The following is a description of a gene set: Genes down-regulated in NB4 cells (acute promyelocytic leukemia, APL) in response to tretinoin; based on Chip-seq data. from publication Martens JH, Brinkman AB, Simmer F, Francoijs KJ, Nebbioso A, Ferrara F, Altucci L, Stunnenberg HG (PMID 20159609) Human Gene Set: MARTENS_TRETINOIN_RESPONSE_DN species: Homo sapiens Many different molecular mechanisms have been associated with PML-RARalpha-dependent transformation of hematopoietic progenitors. Here, we identified high confidence PML-RARalpha binding sites in an acute promyelocytic leukemia (APL) cell line and in two APL primary blasts. We found colocalization of PML-RARalpha with RXR to the vast majority of these binding regions. Genome-wide epigenetic studies revealed that treatment with pharmacological doses of all-trans retinoic acid induces changes in H3 acetylation, but not H3K27me3, H3K9me3, or DNA methylation at the PML-RARalpha/RXR binding sites or at nearby target genes. Our results suggest that PML-RARalpha/RXR functions as a local chromatin modulator and that specific recruitment of histone deacetylase activities to genes important for hematopoietic differentiation, RAR signaling, and epigenetic control is crucial to its transforming potential., and this is the list of marker genes: TUFM, PTMA, DMAC1, MMACHC, HMGA1, C2orf69, ZNF594, VMA21, PNN, SNORD52, NDUFA11, HSP90AB1, GLA, RACK1, AK2, TUBB1, ATP5MC3, RRP7BP, MYBBP1A, ITPKA, TRIM65, H2AJ, FAM180B, H3C13, NUDT16L1 (nudix hydrolase 16 like 1), PRMT6, TBRG4, C11orf91, YDJC, REXO4, HSD17B8, SRSF1, HNRNPH1, TUBB3, RPL26, FARSA, PRRG2, PSMD7, CABLES2, EIF5A, UNCX, CITED4, CHRNG, THUMPD3, ZBTB3, ZNF512B, LDHB, PROCA1, RPL21P28, ZNF785, ELOVL1, RABEP1, NOP16, RFC4, PDHB, PABPN1, RPL13AP20, FRAT1, FAM120AOS, SFT2D3, GNRHR2, CDT1, MRPL57, KIAA1143, GTPBP8, MICAL1, UNC79, ENTR1, RPL5, TMEM102, CHCHD2, TRAPPC4, VIM, ZNF324, HNRNPK, TIGD5, TSSK6, ABT1, ZBTB33 (zinc finger and BTB domain containing 33), H4C5, SNORD33, RASSF1, ESD (esterase D), NABP1, NDUFA4L2, CCDC54, SNORD19B, RXFP4, ERAL1, HOXC11, TEKT2, H4C16, KIAA1586, CEBPB, FAM136A, TMEM216, CSNK1D, COX17, CYTL1, RABGGTB, CCNA2, RECQL4, GLS2, C8orf33, OR7G2, IRX3, NLE1, CD68, RAN, C6orf120, FBXL18, RPS23, HMGN2, ZNF598, RPL24, UMPS, PHOX2A, MRPS7, MIR1915HG, TLCD1, H3C3, MALSU1, ACADVL, SNORA56, MAPK7, POU4F2, PA2G4, UQCRQ, FBXW9, SLC35A2, ZNF628, NDUFB10, WFIKKN1, NAA50, CDV3, RPL34, IL2RG, TUBA1C, ANKRD49, GLT8D1, ARRDC3, SCO2, RRAS, MCM6, BABAM1, RPS8, ATG4D, SLC43A3, FOSL1, HNRNPM, ARL4D, IDH3B, CNPY2, IQCG, SLC2A4RG, IQCC, NFE2L3, SNORD24, SNORD86, MRPS16, RPL37, THAP7, EME2, NDUFB11, TRIAP1, ACD, HDGF, LAT2, C6orf132, KLF1, PRSS53 (serine protease 53), RFESD, ATP5F1E, RPL23, UQCRB, FAM89B, RPL30, IFT22, TYSND1, NAXE, PURB, METRN, RAB26, PPIB, PRMT1, RNF5, RPS4X, AQP11, NRN1L, EIF5, SCNM1, MFSD4B, PDCD4, C20orf204, SLC38A2, SYNGR2, HYAL3, SNORD4A, MYL6B, CCT4, MAZ, CIMAP1B, THAP1, SNHG4, HNRNPL, RPS9, HNRNPDL, EEF1A1, RASL11A, KAZALD1, EIF5AL1, DCXR, PCBP1, RPL35, RPS16, SOX18, TRIM28, TMEM138, SNORA63, PPCS, TMEM129, TSR1, C6orf62, UBL4A, RPL13A, NIP7, CCT5, E2F8, FGFBP3, MYL5, REX1BD, ZNF200, EIF4A2, NOG, TCP1, MKRN3, RPL36, ARRDC1-AS1, PRTN3, ATF4, FRAT2, RPL10, PRDX5, BRICD5, PRR22, C1orf43, TRNT1, FZD1, TRIM41, RPS6KB2, HOXD13, ZSCAN32, PABPC1, TRIM72, RPL9, RPL18A, ATRAID, SNORD21, RPSA, HAGHL, OXLD1, CYP27B1, DRAP1, SNORA62, ZFAS1, RPL23A, RAD23A, SETD9, CDK1, MTRF1L (NCBI Gene Id 54516), HPS6, ACP4, SLFN13, HDC, KLK10, ANTKMT, ZNF646, ZNF281, SUPT4H1 (NCBI Gene Id 6827), ZNF426, DDX3X, HNRNPH3, CCDC85B (NCBI Gene Id 11007), PSME3, RALGPS2, SNRPE, GPR85, DDIT3, POLR1G, PSMG2, TGIF1, NECAB3, SSNA1, HIGD2A, TIMM8A, KLHDC9, SETMAR, TENT5C, ZBTB6, CBX2, GRWD1 (glutamate rich WD repeat containing 1), GEMIN4, MAML1, FABP5, H4C8, MYO1G, POLR1C, RAP2C, MIR646HG, RDH5, PPP1R3F, ERP29, RPL37A, RPL17, ARFRP1, RPL29, IHO1, CDCA7, THAP5, TMEM88, ZBTB48, DDX49, AEBP1 (AE binding protein 1), PLD6, PPIA, H2AX, FTH1, PTOV1, LSM5, SPATA25, MRPS18C, WEE1, TMEM140, RPL32, DNAAF2, CIMIP2A, FMC1, APOA2, JAGN1, TMEM126B, PNPLA2, SNORA29, GPBAR1, TMSB4XP1, RFWD3, NSMCE3, VWA5B2, UQCC5, PRSS12, POP7, HSPA5, CCNL1, COPS6, ATP5MC1, MRPL40 (mitochondrial ribosomal protein L40), CLNS1A, H2BC4, ACTG1 (actin gamma 1), EEF1A1P9, STMN1, MATR3, SEPTIN5, H2AC11, TIMM17B, GNL3, NDUFAF3, CALM2, PTPRCAP, C1QL4, LSMEM2 (NCBI Gene Id 132228), ZNF397, RPL4, MARCKSL1, IRAK3, IRF2BP1 (NCBI Gene Id 26145), USP1, SPRYD4, CYCS, HMGB1, SNORD102, MC1R, ACAT2, TAF7, LAIR1, TMEM208, SNORA4, METTL18, TYMS, MEPCE (NCBI Gene Id 56257), GRK2, GJD3, MRPL4, DDX51, SNORA27, SNORA70, FDX2, ROMO1, PAQR4, RNASE13, IFT20, CCNJ, TAMALIN, TEDC2, NUDT19, RPL27, PDE4DIP, PLK1, BLOC1S3, RBMX, EIF1, FOXO4, EXO5, ZNHIT2, DKC1, PHB2, LINC00173, HNRNPA1P7, MUTYH, H3C4, SLC30A1, MRPL12, PIGW, PCNA, DDX5, PGAM2 (NCBI Gene Id 5224), B2M, IMP4, HNRNPU (NCBI Gene Id 3192), FAM201A, ZNF22, LRRC75A (NCBI Gene Id 388341), PTGES2, SMIM19 (NCBI Gene Id 114926), SNORA81, EIF2S3, RNPC3, KEAP1, WDR73, RPL15, SNAPIN, LGALS2 (NCBI Gene Id 3957), CXorf65, RPS24, CLIP1, HDAC10, MLX, WT1-AS, JUN, SLC35B2, SNORD34, MIR17HG, RBM3, BAX (BCL2 associated X, apoptosis regulator), RPS10, COASY, TIMM10B, IL17RE, C10orf95, HSPD1, RNF167, IZUMO1, COX4I1, NANOS1, NPM3, RBM15B, MPO, TMEM107, CLP1, MRPL11, EEF1B2, CDKN2AIP, ZNF629, NME3, PEX12, SNX22, TNFRSF13C, PCIF1, OR7A11P, LYRM2, CITED2, UBB, CKS2, HMBS, NOLC1 (nucleolar and coiled-body phosphoprotein 1), PAICS, RPS6, CCDC78, THTPA (thiamine triphosphatase), TCEAL1, NGLY1, ZIC2, CACYBP, PRAP1, NEURL2, RPL11, CHMP4A, RPS27, CERS2, DDN, TROAP, UCHL5, NF1, TELO2, EHD2, ZNF79, SOX4, TEDC1 (tubulin epsilon and delta complex 1), GMPPB, SSBP1, MAN2C1, ETAA1, HMGB3, CAND2, POLR2L, ZBTB45, DARS2, SLA2, TBCC, SNORA6, MIF4GD, TMPO, CARNS1, ENDOG, ARVCF, H3-3B, MORN1, CBX3, SRP9, MYL12A, NUP58, GPS2, PRPF38B, UGP2, TMEM126A, CYB561D2, FBXO5, SOX12, PTP4A1, GON7, H2BC12, RPS25, SLC43A1, LETMD1, ADO, RPS27A, CIRBP, RHBDD3, ZNF513, RPLP0, AZU1, NTN3, LRRC41, CMTR2, DRAM2, XBP1, CA14, RPS14, PHF10, PCF11, HES1, EIF3G, SNHG12, DDX56, MGAT2 (NCBI Gene Id 4247), TRNAU1AP, RPL23P8 (ribosomal protein L23 pseudogene 8), POLD2, STOML2, DBP, RPS19, SNORD118, HENMT1, TM7SF2, SNRNP35, PSENEN, ZDHHC6, REC8, PNMA1, HNRNPA1, ARL6IP4, IRF2BP2, HOXA11, RPS3, APEH, LPO, RPL19, TMSB4XP2, PHF23 (NCBI Gene Id 79142), GOLT1B, ZCCHC3, GPR150, LINC01560, DCAF16, CFB, CTSC, NAP1L4, DIPK1B, RPL31, RPS5, MRPL2, BIRC5, CHMP2A, TGFB1I1, APRT, HSPE1, SNX5, H4C1, CFAP119, KCNJ14, SLC29A2, E2F1, RPL10A, NKAPD1, ATXN2L, H2BC21 (NCBI Gene Id 8349), HCFC1R1, DNAJC19, CENPM, ORC6, HSPB1, RRP7A, TRMT10C, MTX1, CCL5, METTL1, SRSF6, WDR38, SYCP3, PRG2, REST (RE1 silencing transcription factor), DUT, MFAP1, RNF126P1, TIMM13, MAD2L1, TRIM13, RAP2B, RPL7, HSPA8, AURKA, GPR152, SNORD43 (small nucleolar RNA, C/D box 43), NONO, MCM9, ABHD14A, COMTD1, UXT, LENG9, GPATCH4, BORCS6, ZNF770, CLN5, FLAD1 (NCBI Gene Id 80308), TFAP4, IMPDH2, MAGEF1, SERHL, ORAI1, PGLS, ZNF276, SPHK2, GFI1, MOCS3, TUBA1B, HPDL, FUT1, LIAS, DENND4C, HNRNPA0, HNRNPF, CARD8, CCT6A, STRADA, C1orf52, GP1BA, CDK16, SPNS2 (NCBI Gene Id 124976), MTIF2, NRROS, ELL3, PURA, ANKRD13D, CLEC11A, RPL7L1, ZNF669, TRIB3, TXNDC17 (thioredoxin domain containing 17), TMED6, NME1-NME2, HOMER3, SNORA61, ATG3, CXCL8, SS18L2, FAM216A, TSPOAP1, MRPL51 (NCBI Gene Id 51258), TP53RK, CPXM1, SIGMAR1, SNORA44, SYCE2, ZFP36L2, TIMM10, TMEM179B, PKMYT1, YBX1, TMUB2, LONRF1, MID1IP1, TIMM8B, MAT2A, DNASE1L2, CRAMP1 (cramped chromatin regulator homolog 1), ANPEP, NEIL1, COCH, C15orf61, TEFM, RGS16, MSH5, CHST14, WDR6, RPL7A, ZBTB14, MAGOHB, SLIRP, C8orf82, EIF3J, CCL3, MFSD3, SRSF7 (NCBI Gene Id 87459), SNORD110, CNBP, CENATAC, SMARCC1, WT1, TEX30, SETD6, ADAT2, MRPS34, CLECL1P, HNRNPA3, RPL14, LRRC14, MBD3, FSTL3 (NCBI Gene Id 10272), NAA38, HMGN1, EFEMP2, METTL23, NT5DC2, MXD3, RPL18, HINT1, CREB3L4, GNB3, PDCD2, PCLAF, SMCHD1, PSMG3, TARDBP, RPL21, NR2F2, SAP18, RSL1D1, H2AC6, DOK3, TMEM186, SNORD2, ZNF655, TOE1, MPLKIP, GLUL, RPL3, TMSB4X, ADGRA2, FADD, PUSL1, RNH1, SRR, C16orf86, CCDC121, ATF5, NT5C, ABHD1, LINC02210, MIR1248, RRM2, SNORD32A, OR10A6, NXT1, MRM1, MCM3, TMEM258, HNRNPA2B1, AIMP2, DHPS, S1PR4, SERBP1, TSPAN31, EXOSC8, GPR62, TXNIP, ASCL2, PRELID3A, SPN, CENPV, CCND2, H2BC7, FUOM, SNHG11, KRT10, SFPQ, RRS1, NOP56, C19orf48P, COX7C, SLC20A1, SNORA41, SRM, MANEAL, SLC1A5, RAD1, CALR, SNORD55, MYC, CORO1B, FKBP2, PGP, RPS12, AOC2, VPS9D1, TRIM75, MRPL34, PUS1, GGCT (NCBI Gene Id 79017), UTP3, MGST1